Given this list of marker genes Zfyve19, Kif14, Celf2, Exoc2, Ankrd45, Kif23, Tsg101, Il16, Usp3, Rala, Vps4b, Capg, Racgap1, Foxl2, C9orf72, Exoc4, Cep55, Vps4a, Pdcd6ip, Cntrl, Exoc1, Exoc7, Stk17b, Nup62, Arf6, Exoc6, Mical3, Ist1, Chmp4c, Or2a7, Birc6, Ccdc66, Agap2, here is a description of the gene set: Mouse Gene Set: GOCC_FLEMMING_BODY A cell part that is the central region of the midbody characterized by a gap in alpha-tubulin staining. It is a dense structure of antiparallel microtubules from the central spindle in the middle of the intercellular bridge. species: Mus musculus